The following is a description of a gene set: studied in species Homo sapiens Reactome Pathway: Base Excision Repair Of the three major pathways involved in the repair of nucleotide damage in DNA, base excision repair (BER) involves the greatest number of individual enzymatic activities. This is the consequence of the numerous individual glycosylases, each of which recognizes and removes a specific modified base(s) from DNA. BER is responsible for the repair of the most prevalent types of DNA lesions, oxidatively damaged DNA bases, which arise as a consequence of reactive oxygen species generated by normal mitochondrial metabolism or by oxidative free radicals resulting from ionizing radiation, lipid peroxidation or activated phagocytic cells. BER is a two-step process initiated by one of the DNA glycosylases that recognizes a specific modified base(s) and removes that base through the catalytic cleavage of the glycosydic bond, leaving an abasic site without disruption of the phosphate-sugar DNA backbone. Subsequently, abasic sites are resolved by a series of enzymes that cleave the backbone, insert the replacement residue(s), and ligate the DNA strand. BER may occur by either a single-nucleotide replacement pathway or a multiple-nucleotide patch replacement pathway, depending on the structure of the terminal sugar phosphate residue. The glycosylases found in human cells recognize "foreign adducts" and not standard functional modifications such as DNA methylation. part of: DNA Repair, and this is the list of marker genes: UNG, H2BC13, RFC4, H2BC11 (H2B clustered histone 11), H2AC6, PARP2, LIG1, POLE3, POLD3, H2BC4, RFC3, H2AB1, H2BC1, H2BC12, MPG, FEN1, H2BC12L, H2BC17, ADPRS, POT1, H2AX, TDG, H2BC15, H2AC7, OGG1, TINF2, H2AC20 (H2A clustered histone 20), H2AJ, RFC1, H2BC9, TERF2, XRCC1, H2BC3, APEX1, POLD4, RFC2, POLE4, RPA2, H3-4, PCNA, ACD, H2BC5, SMUG1, TERF2IP, RPA3, NEIL1, RFC5, H2AC14, TERF1, H2AC18, NEIL3, PARP1, H2BC26, H2BC14, NEIL2, H2BC21, H4C1, POLD2, POLE, MUTYH, POLE2, H2AZ2, PARG, POLB, H2AC4, MBD4, POLD1, NTHL1, PNKP, LIG3, RPA1